The following is a description of a gene set: Genes up-regulated in comparison of macrophages exposed to L. major versus macrophages exposed to 50 worms/well B. malayi. species: Homo sapiens Monocyte-derived dendritic cells (DC) and macrophages (MΦ) generated in vitro from the same individual blood donors were exposed to five different pathogens, and gene expression profiles were assessed by microarray analysis. Responses to Mycobacterium tuberculosis and to phylogenetically distinct protozoan (Leishmania major, L. donovani, Toxoplasma gondii) and helminth (Brugia malayi) parasites were examined, each of which produces chronic infections in humans yet vary considerably in the nature of the immune responses they trigger. from publication Chaussabel D, Semnani RT, McDowell MA, Sacks D, Sher A, Nutman TB (PMID 12663451) Human Gene Set: GSE360_L_MAJOR_VS_B_MALAYI_HIGH_DOSE_MAC_UP, and this is the list of marker genes: ABI1, HSP90AA1, SYN2, MYOZ2, CYB5R3, DDX3Y, SYNPO, MAPK8IP1, VTI1B, DACH1, SPAG6, EOLA2-DT, IL1RN, AKAP8L, RAPGEF2, CACNB1, PAEP, KTN1, HNRNPF, GNAT1, SOX15, SLC11A2, MAP3K8, MAPK8, MISP, BRINP1, MT2A, REG1CP, CEP104, GK, KCNJ10, ACTG2 (NCBI Gene Id 72), PRKACA, BRCA1, CXCL8, CXCL1, SLC16A3, PLA2G7, LCP2, HEG1, BPGM, MMP10, PIAS1, RYR1, ZNF638, NFKB1, CLCN4, MTMR9, CYP1B1, NF1, DVL3, PLA2R1, ALG13, ZBTB17, SMURF2, KLRA1P, GSK3B, SLC30A4, MDC1, CTNNB1 (catenin beta 1), MAP3K9, SLC35D2, RNF126, LAMB3, PLN, LBX1, MT1X, IRS1, CXCL3, SYN3, RNFT2, DNAH7, CD44, TRAF1 (NCBI Gene Id 7185), INSL3, KYNU, MSMB, MMRN1, BMP6, CD6, NR1H2, H2BC7, HSPA4, PLAUR, PAX6, P4HA2, BCAS2, NRP2, DAAM1, PRSS16, AOC2, EPOR, PDE4B, NUP58, TSPYL1, PFDN6 (NCBI Gene Id 10471), NALF1, ACADL, DDX52 (DExD-box helicase 52), TNFAIP3, DLST, G0S2, POM121L9P, KIF5C, AQP7, VWA8, PTGES, DYNC1I1, ACTN1, TNFRSF4, MT1H, GRIK1, SLC18A2, AMOTL2, GTF2H4, MT1F, DUSP5, PLIN1, EPB41, MSX2P1, NQO1, SP100, MARCKSL1, S100A10, NAV3, SLC6A5, GREM1 (NCBI Gene Id 7947), ACRV1, PCSK5 (NCBI Gene Id 96284), TDG, GTPBP10, TNIP1, MIR22HG, PMCH, COL17A1, GTF2A1, IL12B, FCAR, SLC13A3, ZIC3, RPGRIP1, PDPN, GPR4, OLR1, CCL20, RIMBP2, PTP4A1, MT1G, KHDRBS3, TOP1, LITAF, SERPINI2, GPR35, PPBPP2, DUSP4, GAB1, CTSL, CALCA, TGDS, GRB14, PCLO, DHH, SLC20A1, PON1, MT3, NFKBIA, TAF12, TNNC2, CLIC2, MSC, TFRC, SREK1IP1, PLK1, MYL4, IL1B, PRELP, TANK, HLX, CAPN11, GSE1, MT1A, DPP6, GPR137B, AQP9, CASP1, WIPF1, ZNF44, HNF1A, ARC (activity regulated cytoskeleton associated protein), BMP1, CCR7, GALNT18, ALCAM, BAAT, ANXA1, AFM, KRIT1, IL3RA, TNFAIP6, CFLAR